Given this list of marker genes Lef1, Fgf2, Ipo7, Ctnnb1, Bmp4, Rptor, Serpine1, Bmp2, here is a description of the gene set: Mouse Gene Set: GOBP_POSITIVE_REGULATION_OF_NEUROEPITHELIAL_CELL_DIFFERENTIATION Any process that activates or increases the frequency, rate or extent of neuroepithelial cell differentiation. species: Mus musculus